The following is a description of a gene set: HSP90 chaperone cycle for steroid hormone receptors (SHR) in the presence of ligand species: Homo sapiens Human Gene Set: REACTOME_HSP90_CHAPERONE_CYCLE_FOR_STEROID_HORMONE_RECEPTORS_SHR_IN_THE_PRESENCE_OF_LIGAND, and this is the list of marker genes: TUBA3E, TUBA3C, NR3C2, TUBB1, DCTN6 (NCBI Gene Id 10671), FKBP4, TUBAL3, DCTN1, NR3C1, STIP1, DYNC1I2, DNAJB1, TUBA4A, DNAJA1, PGR, DCTN3, TUBA1C, TUBB4B, TUBA1B, HSPA1A, HSPA1B, DCTN4, DYNC1LI1, CAPZA2, TUBB8 (NCBI Gene Id 347688), DNAJA4, DYNLL2, DCTN5, HSPA8, FKBP5, TUBB6, TUBA1A, DNAJA2, HSPA2, ACTR10, TUBA8, PTGES3, HSP90AB1, DYNC1H1, AR, ACTR1A (actin related protein 1A), TUBB2B (NCBI Gene Id 347733), TUBA4B, DYNLL1, DYNC1LI2, TUBB2A, CAPZA3, DCTN2, CAPZB, DYNC1I1, HSPA1L, TUBB8B (NCBI Gene Id 260334), HSP90AA1, CAPZA1, TUBA3D, TUBB3, TUBB4A